Given this list of marker genes MYCN, SLC18A2, PHOX2B, LIN28B, HACE1, KIF1B, ALK, LMO1, here is a description of the gene set: studied in species Homo sapiens An increased concentration of homovanillic acid in the urine. Human Gene Set: HP_ELEVATED_URINARY_HOMOVANILLIC_ACID Elevated urinary homovanillic acid